Given this list of marker genes PTPN11 (NCBI Gene Id 84990), TNRC6B, CBFB, AGO1, CCND3, AGO4, AGO3, CCND2, CCND1, RUNX1, SRC, PML, CDK6, TNRC6C, TNRC6A, AGO2, MOV10, here is a description of the gene set: Human Gene Set: REACTOME_REGULATION_OF_RUNX1_EXPRESSION_AND_ACTIVITY Regulation of RUNX1 Expression and Activity species: Homo sapiens